Given this list of marker genes PCDHGA12, LYPD6, RNASE13, PPP1CA, TEX36, FBXO41, ZNF831, NHLH1, MTHFR, SPN, TTF2, S1PR2, MTCL2, KSR2, NR6A1, TSPAN11, GFAP, IQSEC3, GRIP2, SLC34A2, ELMOD1, C17orf107, KCNK3, EHD3, PCDHGA7, PCDHGA4, SEC23IP, HSDL1, GPAT2, LOXHD1, HCCS, TJP1, GGA3, PPP1R10, CALN1, POPDC3 (NCBI Gene Id 64208), PCDHGB2, EGLN3, MS4A15, PRKCG, SEPTIN5, CAPN12, SLC6A9, CSKMT, FGF18, PPP1R9B, PCDHGB4, SUPT7L (SPT7 like, STAGA complex subunit gamma), PCDHGA10, FOXN3, OPRM1, PALM, GAB2, VCF2, DMWD, PSMD5, ZDHHC23, MLLT6, KIF17, SLC25A14, WDR72, POU3F3, ENTPD3, IL6R, SUSD2, ITGA5, VSTM4, CELF6, MAPK1, MAT2A, FGF19, SLC17A2, PCDHGB5, FAM228B, RARB, PCDHGC3, SRCAP, CARMIL3, PCDHGB3, PCDHGA2, FBLN1, TMEM127, LZTS3, NAA40, ZNF106, PCDHGA5, AAK1, UNC5B, TRIM71, APOM, PXN, SPIB, ADGRG2 (adhesion G protein-coupled receptor G2), ANKIB1, ATXN1L, PCDHGA6, ATP8B2, CCSER2, GABRG3, FUT11, RNF170, DCTN5, PCDHGA3, PCDHGB6, PAK6-AS1, STX17, ATF6B, ZNF687, SLC38A7, CIC, SALL1, PCDHGA11, GALNT15, PPP1R1B, PCDHGB1, PCDHGC5, SNX12, BCL2L1, ARID3B, KCNJ10, MEIS2, LASP1, MAT1A, UBXN4, PCDHGA1, NRIP2, NUMA1, HACD3, NAGA, TSPAN2, MBD6, THRA, ZNF559, PCDHGA8, MMUT, ARFIP1, ABCC10, TOX3, STAM2, DAGLA, NAV1, ITPRIP, TEAD1, BAK1, CNGB1, CPLX2, PCDHGA9, KCNMA1, PCDHGC4, SOX6, CCDC178, SON, LZTS1, CASKIN1, PCDHGB7 (NCBI Gene Id 56099), KDELR1, OSBPL7, ARL10, BBIP1, HEYL, AKIRIN1, TET3, RGSL1, MBOAT7, CLDN19, ABCB9, RANBP1, SAMD12, XPO7, here is a description of the gene set: species: Homo sapiens Human Gene Set: MIR4667_5P from publication Chen Y, Wang X (PMID 31504780) Genes predicted to be targets of miRBase v22 microRNA hsa-miR-4667-5p in miRDB v6.0 with MirTarget v4 prediction scores > 80 (high confidence targets).